The following is a description of a gene set: species: Homo sapiens Genes up-regulated in dendritic cells: anti-FcgRIIB versus inflammatory cytokine cocktail. The ability of dendritic cells (DCs) to activate immunity is linked to their maturation status. In prior studies we have shown that selective antibody-mediated blockade of inhibitory FcgRIIB receptor on human DCs in the presence of activating immunoglobulin (Ig) ligands leads to DC maturation and enhanced immunity to antibody-coated tumor cells. Here we show that Fcg receptor (FcgR) mediated activation of human monocytes and monocyte-derived DCs is associated with a distinct gene expression pattern, including several inflammation associated chemokines as well as type 1 interferon (IFN) response genes including the activation of signal transducer and activator of transcription 1 (STAT1). from publication Dhodapkar KM, Banerjee D, Connolly J, Kukreja A, Matayeva E, Veri MC, Ravetch JV, Steinman RM, Dhodapkar MV (PMID 17502666) Human Gene Set: GSE7509_FCGRIIB_VS_TNFA_IL1B_IL6_PGE_STIM_DC_UP, and this is the list of marker genes: TMEM147, ELOA, PPP2R1B, SELENOW, CLN5, ISOC1, PSMD2, EXTL3, RYK, GPX1, ODC1, SLC25A12, COPS7A, SRM, SNAP47, NUBP1, LHFPL2, IFT22, PSMD10, SESN3, MRPL50, SERPINF1, RNF141, MAP2K1, CMBL, MMGT1, SUPT7L, TXNL1, MRPL38, NCBP1 (NCBI Gene Id 4686), WDR1, SQSTM1, MAEA, SEPTIN10, FLNB, DPH6, SEC23A, ELMO2, ARMC1, MED6, KBTBD7, CLPP, RAB3D, PPP3R1, LRRC41, DIS3L (NCBI Gene Id 115752), MMP2, IDH2, BTD, CHCHD5, EHD4, PSMD6, COMMD2, FIZ1, KPNB1, TMEM123, CRIP2, STAU1, HINT3, CINP, ADI1, POLDIP2, MED16, TUT1, RFC3, LAP3, SNU13, TTLL12, CST3, YIPF1, HSP90AB1, OTUB1 (OTU deubiquitinase, ubiquitin aldehyde binding 1), VAMP3, SMU1, GNAI2 (G protein subunit alpha i2), YARS1, LY96, PPA2, GAMT, POLD2, PLRG1, DUSP22, KCTD5, RPLP0, PSMG2, IFNGR1, AP2B1, COMMD7, MLF2, PSMD7, POLR1H, INTS9, IDS, DRG1, ALYREF, TUBG1, CAPN6, UCK2, PRKAR2B, PARVB, EIF3L, CYRIB, PLS3, HEXIM2, STRADA, GALM, SGF29, CCL8, RRN3, NIT2, ECHS1, FKBP1A, SEC23B, AHCYL2, CPNE3, GABARAPL2, MAOA, AP2M1 (adaptor related protein complex 2 subunit mu 1), EIF1AD, RHOA, DNAJA2, P3H2, MCEE, TNFAIP1, EMC4, GYG1, PPP1CC, EIF3I, HIBADH, PLP1, PRMT7, SKIC8, SLC25A3, UBA2, TIMM23, RBMS2, EFTUD2, HNRNPK, DUSP18, CPT1A, RAP1B, DDAH1, NSF, RACK1, DDX21, MICU1, GLTP (glycolipid transfer protein), CHAC2 (NCBI Gene Id 494143, ChaC glutathione specific gamma-glutamylcyclotransferase 2), GINS4, PSMD1, PNRC2, PPP1R7, VAMP7, ASH2L, DBI, RNASEH2A, SHMT2, DCAF12L1, RHEB, TIMM17B, ARPP19, NFATC3 (NCBI Gene Id 82543), AMD1, EIF2B3, FUNDC2, PRR13, MAPK3, TRAPPC1, SMPDL3A, EMP1, H2AZ2, RAB9A (NCBI Gene Id 9367), RAB11A, NMRAL1, EIF4E2 (NCBI Gene Id 9470), CAND1, NAXE, ECI2, EMB, NIPSNAP1, CAPRIN1, MREG, PFN2, DCTN5, ARMCX2